The following is a description of a gene set: studied in species Homo sapiens A major challenge for kidney transplantation is balancing the need for immunosuppression to prevent rejection, while minimizing drug-induced toxicities. We used DNA microarrays (HG-U95Av2 GeneChips, Affymetrix) to determine gene expression profiles for kidney biopsies and peripheral blood lymphocytes (PBLs) in transplant patients including normal donor kidneys, well-functioning transplants without rejection, kidneys undergoing acute rejection, and transplants with renal dysfunction without rejection. We developed a data analysis schema based on expression signal determination, class comparison and prediction, hierarchical clustering, statistical power analysis and real-time quantitative PCR validation. We identified distinct gene expression signatures for both biopsies and PBLs that correlated significantly with each of the different classes of transplant patients. This is the most complete report to date using commercial arrays to identify unique expression signatures in transplant biopsies distinguishing acute rejection, acute dysfunction without rejection and well-functioning transplants with no rejection history. We demonstrate for the first time the successful application of high density DNA chip analysis of PBL as a diagnostic tool for transplantation. The significance of these results, if validated in a multicenter prospective trial, would be the establishment of a metric based on gene expression signatures for monitoring the immune status and immunosuppression of transplanted patients. from publication Flechner SM, Kurian SM, Head SR, Sharp SM, Whisenant TC, Zhang J, Chismar JD, Horvath S, Mondala T, Gilmartin T, Cook DJ, Kay SA, Walker JR, Salomon DR (PMID 15307835) Genes up-regulated in kidney biopsies from patients with well functioning kidneys more than 1-year post transplant compared to the biopsies from normal living kidney donors. Human Gene Set: FLECHNER_BIOPSY_KIDNEY_TRANSPLANT_OK_VS_DONOR_UP, and this is the list of marker genes: NDUFAF1 (NADH:ubiquinone oxidoreductase complex assembly factor 1), CD46, SP3, LUM, PIK3C2A, GOT1, BLTP1, ZMPSTE24, EEF1D, VEGFA, MED13, PTPRD, DYNC1I2, TOP2B, EIF1AX, PPP1R2, CALU, ADH1A, SLC16A4, SUB1, WSB1, SLC39A6, C7, SEM1, SNRPD3, PTGES3, JCHAIN (NCBI Gene Id 3512), BBX, ZDHHC17, CRYAA, USP33, CNBP, RALBP1, TM9SF1, TWF1 (twinfilin actin binding protein 1), PTPN12, ID2, GSN, COL1A2, CD74, ACSL4, PKN2, H2AZ1, PFN2, UGT8, HLA-DQA1, CRYAB, ATP6V0E1, UBA2, NBN, AHCYL1, PSMC5, UGCG, HLA-F, PLS3, PTPRC, MTMR4, SLC17A3, HSBP1, HSPA8, YWHAH, BCAP31, RFK, NARS1, IGFBP4, TOB1, VTI1B, SAP18, TRAPPC8, RBL2, TSPAN8, SEC23A, IDH1, ZEB1, SMG1, RBP4, TXNL4A, COPA, H2AZ2, NEK7, NCOA2, SNRPN, GBE1, CREB3L2, CYB5R3, MEGF9, CREB1, CDK2AP1, CRYZ, MMP7, ZBTB20, MYH10, PPP2R5C, SPARC, RGS5, RAB29, NIPSNAP2, YWHAE, CFLAR, CAT, TGFBR2, RRAGA, LEPROT, TFPI, IFNGR1, HSD17B4, CLDN10, ATP8A1 (NCBI Gene Id 10396), PLOD2, ARID5B, DYNLL1, EVI2B, SRRM1, N4BP1, HNRNPA2B1, CREBBP, CDH11, PSME2, HSPA5, ALG8, IL32, PDCD6, NPTN, F2RL1, GABBR1, MYO1B, NACA (NCBI Gene Id 4666), VCAN, HNRNPC (heterogeneous nuclear ribonucleoprotein C), SCAF11, LYZ (NCBI Gene Id 4069), CCT2, PEX11B, SULT1A2, ANK3, TANK, HDGF (NCBI Gene Id 92300), GCH1, ATF2, HMGN4, PALLD, PLSCR1, COPS5, LASP1, ARHGEF18, CXCL12, RCAN1, IGLC2, COL4A1, MYH11, TBL1X, ATP6V1B2, BBOX1, JTB, RBPMS, CAPZA1, HLA-DRB1, DDX5, GDI2, MAOA, AKR1C3, MSN, ACADSB, HLA-DPB1, ETF1, GLS, PICALM, CYP1B1, GSTO1, TUBA1B, CCNG2, OXA1L, CD44, HIPK1, ADD3, FPGT, HPGD, RPP14, F2R, DPM1, ELOVL5, AGL, RTL8C, CREBZF, FHL1, RYK, R3HDM2, MSH3, RSRC2, HLA-DRA, NEK4, CYCS, FAM3C, BTBD3, C1S, OGT, KHK, RAC1, MICU2, RERE, LAMP2, SCAMP1, LTN1, CDC42BPA, MYH9, UGT1A10, GGT1 (gamma-glutamyltransferase 1), FMO3, PTH1R, WEE1, TAPBP, PARK7, SERINC1, SKIC3, GPC3, SLC34A1, AUH, PSMA3, BNIP3, SPTSSA, ASF1A, SLC25A46, EIF3I (eukaryotic translation initiation factor 3 subunit I), TSC22D1, NR1D2, RPL36AL, TBCB, SMAD5, SLC5A3 (solute carrier family 5 member 3), QKI, PAM, PAPSS1, SEPTIN6, LY75, NMI, ATP2A2, PAPPA2, LRRFIP1, AFF1, ACTN1, PEX3, SERINC3, TNFSF10, CDK13, NDUFS1, VIM, ACSM3, TRIM44 (NCBI Gene Id 54765), ATP6V1A, SLC22A2, DNAJA1, RHOA, SPARCL1, ISCA1, CBR4, SSBP1, CD2AP, TRIM2 (tripartite motif containing 2), CYP4A11, PDLIM5, SERP1, RHOBTB3, LITAF, EIF2AK2, RAN, PPM1B, PTP4A2, DEK, WWP1, SH3BGR, AMD1, SEPTIN10, HBB, IFT25, ANP32A, AP3S1, PUM1, MTDH, FNBP1L, SNX2, GBP1, ACBD3, TNPO1 (transportin 1), TBCA, SDCBP, PPID, HERPUD1, CITED2, SRGN, ANXA7, LUC7L3, SIAH1, RBM3, ARF4, RACK1, CNIH1, SLC1A1, NUP50, NSL1, MYOF, ZEB2, HBA1, PARP1 (poly(ADP-ribose) polymerase 1), LEPROTL1, TOMM70, EPS8, DUSP3, GULP1, HAT1, PSMB9, PAFAH1B1, FGL2, BAMBI, PPIB, HLA-G, DYNLT3, E2F3, TOPORS, DDOST, NCOA3, SWAP70, ENPP2, HMGB2, FNTA, MORF4L2, CBX6, HNRNPA1, NONO, MVP (NCBI Gene Id 9961), IGHM, PCK1, NXF1, AOC1, CD9, XPO1, SFRP1, PPP2R1A, ERBB3, HADH, FOXJ3, PLAAT4, ROCK1, ANXA4, H3-3B, SMG1P5, UBE2N, NDUFA5, NNT, PNISR, PSMD11, IGKC, SLC25A1, TUSC3, TMEM123, PRKAR1A, STAT1, OAT, CBX3, BEX4, HNRNPH2, MAPK1IP1L, MDH1, DSTN, FECH, NREP, VAT1, RB1, HLTF, CTNNA1, VCAM1, MRPS18B, HSPA13, DCTD, SCFD1, PRDX4, CLASP2, IL6ST, TUBA1A, NAP1L1, HNRNPDL, ZMYM2, ETFA (NCBI Gene Id 2108), FNDC3A, C11orf58, SRSF1, PRPF40A, AUTS2, GOT2, COMT, ARFGEF1, DESI2, UBQLN2, MAPRE1, TMX1, SEC24B, HBD (hemoglobin subunit delta), MAF, HSPE1, AP3D1, IL7R, FAM168B (NCBI Gene Id 130074), CASP4, CDS1 (NCBI Gene Id 1040), SCP2, UFL1, GUSBP14, GLRX, MORC3, BRD8, PARG, TIAL1, MINPP1, HIBCH, GRB10, CREBL2, ZC3H15, TXNDC9, BMP2K, PGK1, UQCRC1, GALNT1, ACTG1, SELENBP1, G3BP1, PLPBP, C1D, PKM, ADH5, AKR1C1, PSMD14, COPS2, SLC25A13, PRKRA, TARDBP, PRKCI, SMURF2, RPL22, GTF3A, PTMA, RPS6KA3, RAB2A, HNRNPR, ABAT, PSMC6 (NCBI Gene Id 63380), HMGN3, SERBP1, TNFRSF11B, STAT3, HLA-A, OXCT1, TOMM34, LPGAT1, TRRAP, DLD, ID1, KNG1, TCEAL4, TERF1, PHKB, PSMA4, CFDP1, SYPL1, HLA-DPA1, ARMCX2, BZW1, PJA2, KCNJ15, AZIN1, DST, SPCS2, BIRC3, ATG12, PPP2CB, DICER1, GCC2, FABP4, ABI1, SH3BGRL, RAB11A, EIF3F, PHF3, MMUT, TMED5, FAT1, KRIT1, CXCL9, NUP153, RNF6, FYN, GALC, WDFY3, GCSH, TSPO, GTF2I (NCBI Gene Id 90875), NBPF14, ACSL3, SERPINE2, IFI16, MATCAP2, DUT, ZMYND11, CHTOP, EIF4H, ANXA5, TOR1AIP1, TSPYL4, AHR, SRP72, HMGN1, KPNA2, FRMD4B, LRP2, SRSF2, DHX9, IMMT, DYRK1A, CX3CR1 (C-X3-C motif chemokine receptor 1), AK4, CRYM, RAB1A, UBXN4 (NCBI Gene Id 23190), RAP1B, SRSF11, EPS15, WWTR1, WFDC2, MARCKS, MSMO1, ACOT13, TEK, LGALS1, IGF1R, ITM2A, STRN3, RECQL, ACTR2, WASHC4, SEC22B, SHOC2, DPYSL2, ACTA2, RSRP1, ANK2, MCL1, CFH, TMED10, CLU, HSPA1A, DDX3X, RAB8A, PGM1, TRA2A, DDX19B, RALA, UBE4A, COL3A1, COPB1, CA12, ZNF146, CDK14, USP14, HNRNPK, IGHG1, PDIA3, APLP2, NRIP1, FBXO9, ARPC5